Given this list of marker genes Ap3b1, Tyro3, Irak3, Mapkapk2, Cd36, Lrrfip2, Traf3, Gps2, Lrch4, Rps6ka3, Trim30a, Ly96, Cd274, Tlr4, Tlr11, Tnip3, Gdi1 (NCBI Gene Id 14567), Tlr5, S100a8, App, Arrb2, Tlr7 (NCBI Gene Id 170743), Tlr8, Lrrc14, Tlr1, Myd88, Rnf115 (NCBI Gene Id 99831), Rab11fip2, Tlr2, Fosl1, Lrrc19 (leucine rich repeat containing 19), Bcl10, Mapkapk3, Rela, S100a9, Tifab, Scimp, Mfhas1, Otud4, Smpdl3b, Hspd1, Tirap, Ccdc134, Nlrp6, Ticam2, Nfkbiz, Pdpk1, Ywhae, Cd300a, Gfi1, Plcg2, Lgr4, Tlr3, Ticam1, Pik3ap1, Ptgs2os, Tlr9, Prkce, Cactin, Irf4, Cd86, Cd300lf, Gpr108, Nfkbil1, Unc93b1, Tlr12, Sarm1 (NCBI Gene Id 97709), Irf1, Tnip1, Irf7, Tlr13, Irf3, Reg3g, Tlr6, Esr1, Tasl, here is a description of the gene set: The series of molecular signals initiated by a ligand binding to a toll-like receptor of a target cell. Toll-like receptors directly bind pattern motifs from a variety of microbial sources to initiate an innate immune response. species: Mus musculus Mouse Gene Set: GOBP_TOLL_LIKE_RECEPTOR_SIGNALING_PATHWAY